Given this list of marker genes ZNF436, NELFA, TMEM230, C1QL1, CCNJ, RAI2, UQCRB, PCBP1, ZNF518B, ACP5, SEC63, MAP2K1, ATP5F1A, PAPOLA, LGALS4, ST8SIA2, NYNRIN, C15orf39, DDX4, ACRV1, STT3B, NRL, PSMD14, SMARCE1, PSPC1, TLL1, IGF2BP2, PNRC1, CPSF3, HAUS6, ROCK2, PPP2R5A, NOL7, ST6GALNAC1, MED1, GLB1, FBP2, NDFIP2, FBXL15, BNIP1, DFFB, PPP1R21, CHMP1B, BAIAP2L1, AARD, MRPL23, S100A3 (S100 calcium binding protein A3), TMED1, PXK, GRPEL2, DLX6, TSFM, METAP2, DCAF11, TRAPPC2L, ANGPTL4, ST6GAL1, PTPRN2, CXXC1, NCF4, RBM26, SLC26A2, SASS6, SRP9, UPP1, ENSG00000286190, MRPL48, ALDH9A1, TRIM46, SCN7A, PGM2, SLC44A1, PTHLH, DDX1, PMM1, NOTCH2, TOMM7, FGF19, PRDX3, NECTIN2, RNF138, CMC2, SLC19A1, MAP2K6, RPS11, CKAP4, GJA10, SLC1A5, RXRG, MAF1, FAM171A1, FOXC2, MYT1, CHD8, CDIP1, DFFA, PIGN, CEBPZOS, PEX6, TRIP6, GTF2F2, NOP10, FGF14, ALOX12B, APOA4, KCTD9, VTN, ABHD17A, LTB, SLC2A5, SURF6, UBL3, RPL41 (ribosomal protein L41), SORD, C16orf89, ACADL, RAB12, WDR75, ALCAM, KDR, ANXA10, SLC50A1, STIL, ANKRD11, TWIST1, MBD4, SFMBT2 (Scm like with four mbt domains 2), RPL18, LSP1, VWF, NKX2-2, FCGR2B, SLC22A18, PISD, NUP93, POLR3A, ADCYAP1, CCT4, TCF4, AKAP4, COMMD2, ICAM2, LUM, ENTPD7, FKBP11, SYNRG, FCRLA, TNNC2, ARL14EP, MRPS26, RTCB, USP5, ASPRV1, CD47, ATM, WIPF1, COL1A1, TCEA2, MS4A1, GNA13, TOB1, PLA2G2C, PHC1, C3AR1, CRIP1 (cysteine rich protein 1), CBX7, TUSC2, CD72, TXNDC5, TSKS, SERPINB4, HAUS5, TCP11, TMEM176A, ACYP1, SEMA3C, FZD6, SMG5, POLR2H, BTK, MMP14, SLC15A2, RELB, YWHAQ, MRPS21, CYP27B1, CX3CR1, OAT, COA6, EIF3G, IGFBP1, FLI1, RAD9A, SPINT1, LAMA1 (laminin subunit alpha 1), MAP4K1, ISL1, TLN1, FAM162A, GABRA2, here is a description of the gene set: species: Homo sapiens Bruton's tyrosine kinase (Btk) is important for B lymphocyte development. To identify genes that are differentially expressed in primary B cells lacking functional Btk, splenocytes from X-linked immunodeficiency (Xid), Btk knockout (KO) and immunocompetent CBA mice, were used in microarrays containing more than genes and expressed sequence tags (ESTs). We found 4515 transcripts expressed in duplicate experiments in all three strains. Out of these, 38 were differentially expressed genes (21 up-regulated >2 fold and 17 down-regulated <-2 fold) between CBA and Btk defective mice. Ten out of these genes were selected and quantitative Real-Time PCR was conducted for validation and further investigation. Real-Time experiments correlated nicely with the microarray data. No definitive phenotypic difference has previously been reported between Xid and Btk KO mice. We found genes, whose expression differed (>2 fold) between the two strains. Moreover, when the genes, which differed between immunocompetent CBA and Btk defective mice were ranked according to fold-increase, the levels in Btk KO mice were significantly more altered. This suggests that the defect in Btk KO mice is more severe and demonstrates that the mutant Btk protein in Xid mice does not generally function as dominant negative form. Human Gene Set: GSE2826_XID_VS_BTK_KO_BCELL_UP from publication Lindvall JM, Blomberg KE, Berglöf A, Yang Q, Smith CI, Islam TC (PMID 15214046) Genes up-regulated in comparison of primary splenic B cells from Xid mice versus those from BTK knockout mice.